The following is a description of a gene set: studied in species Mus musculus The chemical reactions and pathways resulting in the formation of glycolipid, a class of 1,2-di-O-acylglycerols joined at oxygen 3 by a glycosidic linkage to a carbohydrate part (usually a mono-, di- or tri-saccharide). Mouse Gene Set: GOBP_GLYCOLIPID_BIOSYNTHETIC_PROCESS, and this is the list of marker genes: St3gal2, Pigu, Gal3st2, St8sia6, Pigs, Pigyl, Mppe1, St6galnac1, Pigc, B3galt1, Pigx, B4galt3, St6galnac3, Pigz, Fut9, Fa2h, Ugcg, B3galt4, Slc30a5, Pigh, Pigv, St6galnac5, Pigf, Sccpdh, 6430550D23Rik, Pigl, Dpm2, Dpm3, Gal3st3, Pigb, St3gal4, St3gal1, Tm9sf2, Piga, B4galt5, Pgap3, Pigg, St3gal3, Gpaa1, Cwh43, Dpm1, Pigk, Pyurf, St3gal6 (NCBI Gene Id 75513), A4galt, Pigw, St6galnac4, B4galt4, St8sia5, St8sia4, Pigt, Pgap4, Pigq, Fut4, Pigo, Pigp, Gal3st1 (NCBI Gene Id 54452), St6galnac6, Ugt8a, St8sia3 (NCBI Gene Id 20451), A3galt2, B4galt6, B4galnt1, Pgap1, Pigm, B3galt2, Pign, Pgap2 (post-GPI attachment to proteins 2), St8sia2